The following is a description of a gene set: electronically inferred by orthology from the curated human pathway studied in species Mus musculus part of: Cell-Cell communication This event has been computationally inferred from an event that has been demonstrated in another species.<p>The inference is based on the homology mapping from PANTHER. Briefly, reactions for which all involved PhysicalEntities (in input, output and catalyst) have a mapped orthologue/paralogue (for complexes at least 75% of components must have a mapping) are inferred to the other species. Reactome Pathway: Cell junction organization, and this is the list of marker genes: Spcs2, Tmem258, H2bc12, H2bc8, Dnttip1 (NCBI Gene Id 76233), Rela, Psmd1, H2ax, Psma2, Kdm1a, Stt3a, Rbbp7, H2ac8, H3c6, Cdh12, Psmd6, H4c2, Psmd12, Fyn, H2ac24, H3c10, H2ac4, Rack1, Psmb7, H3c2, H3c13, Psma5, H4c17, Col17a1, Smarca4, Krt14, Mtbp, Zmym2, H2bc1, H4c12, Acta1, Spcs1, Psmc1, H2ac12, Ctss, H4c3, H2bc3, H2ac19, Flnc, H3c15, H3c3, Jup, Ddost, H3c4, H3c11, Ezh2, Dad1, H2ac10, Ganab, Pxn, H4c4 (NCBI Gene Id 319156), Cdh2, H3c1, H2ac15, Psmc5, Psmc4, Pard6g, H2ac1, Psmb5, H2bc13, Pomt2, Rbbp4, H2ac23, Fermt2, Cdh5, H2ac7, H2bc7, Tyk2, H2ac13, Ang, Cd151, Cdh8, Nectin2, Vasp, Cdh18, H2ac22, H3c8 (NCBI Gene Id 97908), Dnm2, Banp, Nectin4, H2bc15, Prkcsh, Actg2, Ilf3, H2ac11, Ubb, Cbll1, Psma7, Twist1, H3f3a, H2az2, Cadm3 (cell adhesion molecule 3), Spcs3, Ilk, Il6, Psma3, Psma4, Pomt1, Psmd7, Tesk1, Cdh15, H4c9, Sdk1, H4c8, H2ac20, H2bc27, Fblim1, H2bc9, Psmb6, Psma6, Psmc3, Psmb4, H4c1, H4c6, Psmc6, Cdh3, Lims2, Pard3, Ost4, Sec11c, H2bc11, Ctnnb1, Cdh1, H2bc22, H3c7 (NCBI Gene Id 260423), H2ac6, Psma1, Cdh6, Pip5k1c, Cdc42, H4c18, H4c11 (H4 clustered histone 11), Csnk2b, Psmc2, Cdh7, Pcsk7 (NCBI Gene Id 18554), Adam19, Nfkb1, Psmd13, H4c14, Il6ra, Angptl4, Rps27a, Actc1